The following is a description of a gene set: Human Gene Set: COLLER_MYC_TARGETS_DN from publication Coller HA, Grandori C, Tamayo P, Colbert T, Lander ES, Eisenman RN, Golub TR (PMID 10737792) species: Homo sapiens MYC affects normal and neoplastic cell proliferation by altering gene expression, but the precise pathways remain unclear. We used oligonucleotide microarray analysis of genes and expressed sequence tags to determine changes in gene expression caused by activation of c-MYC in primary human fibroblasts. In these experiments, genes were consistently induced, and genes were repressed. The identity of the genes revealed that MYC may affect many aspects of cell physiology altered in transformed cells: cell growth, cell cycle, adhesion, and cytoskeletal organization. Identified targets possibly linked to MYC's effects on cell growth include the nucleolar proteins nucleolin and fibrillarin, as well as the eukaryotic initiation factor 5A. Among the cell cycle genes identified as targets, the G1 cyclin D2 and the cyclin-dependent kinase binding protein CksHs2 were induced whereas the cyclin-dependent kinase inhibitor p21(Cip1) was repressed. A role for MYC in regulating cell adhesion and structure is suggested by repression of genes encoding the extracellular matrix proteins fibronectin and collagen, and the cytoskeletal protein tropomyosin. A possible mechanism for MYC-mediated apoptosis was revealed by identification of the tumor necrosis factor receptor associated protein TRAP1 as a MYC target. Finally, two immunophilins, peptidyl-prolyl cis-trans isomerase F and FKBP52, the latter of which plays a role in cell division in Arabidopsis, were up-regulated by MYC. We also explored pattern-matching methods as an alternative approach for identifying MYC target genes. The genes that displayed an expression profile most similar to endogenous Myc in microarray-based expression profiling of myeloid differentiation models were highly enriched for MYC target genes. Genes down-regulated in 293T (transformed fetal renal cell) upon expression of MYC., and this is the list of marker genes: CAVIN3 (NCBI Gene Id 8990), COL3A1, NREP (neuronal regeneration related protein), A2M, PDGFRA, CDKN1A, CCN2